Given this list of marker genes Slco1a4, Slco4c1, Slco3a1, Slco1b2, Slco2a1, Slco1c1, Slco4a1, Slco2b1 (NCBI Gene Id 28246), Avp (NCBI Gene Id 11998), Slc16a2, here is a description of the gene set: Transport of organic anions studied in species Mus musculus Mouse Gene Set: REACTOME_TRANSPORT_OF_ORGANIC_ANIONS